Given this list of marker genes Sik2, Pfkfb1, Hnf1a, Kat2b, Myc, Gpi1, Map2k1, Esrrb, Prkn, Prxl2c, Vcp, Ndufc2, Psen1, Gapdhs, Bcl2l1, Mlxipl, Tigar, Src, Mlst8, Il4, Slc4a4, Htr2a, Hif1a, Trem2, Igf1, Bend3, P2rx7, Ppp2ca, Adcy10, Gck, Zbtb20, Mtor, Tmsb4x, Rptor, Adora2b, Gpd1, Ins2, Ppara, Eno1, Uchl1, Mlx, Slc25a12, Eno1b, Stat3, Insr (NCBI Gene Id 319666), Pid1, Prkaa1, App, Ins1, Ifng, Prkaa2, Nos3, Arnt, here is a description of the gene set: Mouse Gene Set: GOBP_POSITIVE_REGULATION_OF_NUCLEOTIDE_METABOLIC_PROCESS Any process that activates or increases the frequency, rate or extent of the chemical reactions and pathways involving nucleotides. species: Mus musculus